Given this list of marker genes ARHGAP18 (Rho GTPase activating protein 18), SERPINB9, IFT57, JAK3, C2orf69 (chromosome 2 open reading frame 69), NMD3, SRFBP1 (NCBI Gene Id 153443), APOL3, CHUK, HPRT1, UGCG, CDC42EP4, SERPINA1, SLC39A14, MFSD14A, CHSY3, CALHM6, COL15A1, ADAM19, DAB2, ZEB2, SAMD4A, IL1B, CTDSP2, COQ10B, DNAJB9, G3BP2, NAP1L1, FAM76B, GASK1B, SRGAP1, ATP11C, ADGRF2P, SAMSN1, CDC27, RRP1B, IL6R, PTGER4, CH25H, RP2, SELL, SLC41A2, RBPJ, THBS1, BLTP3B, MYLIP, NEK6, IL6ST (NCBI Gene Id 3572), ATP2B1, FCGR3B, YWHAG, GCA, DERL1, CXCL1, FTH1P5, ICAM1, BATF3 (basic leucine zipper ATF-like transcription factor 3), PLEK, VCAN, ZNF436, SDCBP, FPR1, CXCL8 (C-X-C motif chemokine ligand 8), IL4R, ARFGAP3, B4GALT5, IL6, DDX21, TNFRSF1A, MT1M, KLF10, IL13RA1, GOLT1B, CDC42EP2, SRGN, MT2A, GBP1 (NCBI Gene Id 2633), DOK5, EIF1AX, DUSP6 (NCBI Gene Id 1848, dual specificity phosphatase 6), PIP4K2A, C3AR1, PRRX1, IL1RL1, GPR65, FCGR2A, IKZF1, RAB3IL1, FGD6, VCAM1, PITPNB, EFHD2, FZD5 (NCBI Gene Id 81561), CDC42EP3, NFIL3, FOSL1, QTRT2, RNF19A, MED13L, PDPN, KPNA4, SEC24D, AHR, BLOC1S6, HDC, IFNGR2, SV2B, CCDC71L, OSMR, PLSCR1, INTS6, C16orf54, APOL2, IRF1, PTP4A2, BASP1, SERPINA3, CD44, MGAT2, CRY1, PHACTR2, RUBCNL (NCBI Gene Id 80183), CCNJ, LILRB2, BIRC3, NRIP3, NABP1, ETS1, DDX3X, ATP13A3, GNAQ, ECPAS, WTAP (WT1 associated protein), IRGQ, PLAUR, ATF1, CDK12, LARP4, MIDN, ATP11A, ELK4, TNFAIP2, LIFR, ATAD1, CSGALNACT2, CXCL10, RAB27A, BCL3 (BCL3 transcription coactivator), ASAP1, RPS6KB1, CCL8, AKAP12, CCN1, CDK17, RHEB (NCBI Gene Id 6009), STX12, IFNGR1, HAPLN3, ACSL4, HGF, POTEKP, GOLPH3, CD83, TAF2, SRSF11, STAU1, PTCSC1, HYCC1, ACKR1, SIN3A, PTPRC, RAB23, UBE2W, ITGAX, FOSL2, FAM3C, BCL2A1, PPP1R15B, CLEC7A, SERPINB1, SOCS3, RYBP, SULF1, ARHGAP31, FCGR1BP, ZNF567, IFI16, SCAF8, CSF2RB, ANKRD28, SERPINE1, STK3, RHOU, ZFP36L1, PRRC2C, SYNJ2, TMEM70, GABPB1, SLC20A1, MRPL44, CXCL3, EML4, GFPT2, NADK2, SH2B3, SPRED1, VEZF1, MECP2, CEMIP2, PAK2, PPP4R2, DHX33, MTMR9, SEC24A, MEDAG (mesenteric estrogen dependent adipogenesis), IRX2, SECTM1, TASOR2, FEM1B, FGR, TNFAIP6, CCDC50, STEAP4, CCNT1, FGL2, VMP1, ZBTB2, STOM (NCBI Gene Id 2040), ZFX, CNN3, TXLNG, NCOA7, TMEM200A, TM4SF1, PCGF5, CIMAP2, MCTP1, TPBG, MIER1, NAMPT, KCNJ15, MTSS2, CCL2, TJP2, ZNF267, CCR1, MYB, PPP3R1, DIMT1, ZPR1, TLR4, CHSY1, UBE2D1, SLC25A37, BZW1, PTX3, MARCKS, SLC2A3, MT1E, RGS16, ABCA1, FAM20A, RIT1, MYO1B, LYN, SSR1 (signal sequence receptor subunit 1), UGDH, PPTC7, CHD1, SIPA1L1, RRN3, GREM1, NR4A3, PATL1, RNF145, APOL6, TGFBR1, CXCL2, ZNF217, SELE, GPR183, NNMT, TSHZ3, CHST15, ARL13B, EIF4E, LYZ, UAP1, SMARCA1, SLC4A7, CTSL, here is a description of the gene set: from publication Patel NP, Vukmanovic-Stejic M, Suarez-Farinas M, Chambers ES, Sandhu D, Fuentes-Duculan J, Mabbott NA, Rustin MHA, Krueger J, Akbar AN (PMID 30247603) studied in species Homo sapiens Human Gene Set: PATEL_SKIN_OF_BODY_ZOSTAVAX_AGE_70_93YO_VZV_CHALLENGE_6HR_UP Genes up-regulated in skin of body 6hr vs 0hr in adults (70-93) (VZV challenge) after exposure to Zostavax, time point 6H Background: The live attenuated vaccine Zostavax was developed to prevent varicella zoster virus (VZV) reactivation that causes herpes zoster (shingles) in older humans. However, the impact of vaccination on the cutaneous response to VZV is not known. Methods: We investigated the response to intradermal VZV antigen challenge before and after Zostavax vaccination in participants > 70 years of age by immunohistological and transcriptomic analyses of skin biopsy specimens collected from the challenge site. Results: Vaccination increased the proportion of VZV-specific CD4+ T cells in the blood and promoted the accumulation of both CD4+ and CD8+ T cells in the skin after VZV antigen challenge. However, Zostavax did not alter the proportion of resident memory T cells (CD4+ and CD8+) or CD4+Foxp3+ regulatory T cells in unchallenged skin. After vaccination, there was increased cutaneous T-cell proliferation at the challenge site and also increased recruitment of T cells from the blood, as indicated by an elevated T-cell migratory gene signature. CD8+ T-cell-associated functional genes were also highly induced in the skin after vaccination. Conclusion: Zostavax vaccination does not alter the abundance of cutaneous resident memory T cells but instead increases the recruitment of VZV-specific T cells from the blood and enhances T-cell activation, particularly cells of the CD8+ subset, in the skin after VZV antigen challenge.